The following is a description of a gene set: Mouse Gene Set: GOMF_PHOSPHATIDYLINOSITOL_PHOSPHATE_PHOSPHATASE_ACTIVITY Catalysis of the reaction: phosphatidylinositol phosphate(n) + H2O = phosphatidylinositol phosphate(n-1) + phosphate. This reaction is the removal of a phosphate group from a phosphatidylinositol phosphate. species: Mus musculus, and this is the list of marker genes: Ptprq, Mtmr14, Mtmr1, Inpp5j, Inpp5d, Mtmr4, Synj1, Mtmr12, Inpp5f, Inpp5b, Inppl1, Inpp4b, Mtmr7, Mtmr11, Inpp5e, Tpte, Synj2, Inpp4a, Sacm1l, Mtmr6, Pip4p1, Inpp5k (inositol polyphosphate 5-phosphatase K), Fig4, Mtmr2, Mtm1, Ptpmt1, Mtmr3, Pten, Pip4p2, Ocrl, Mtmr10